The following is a description of a gene set: studied in species Mus musculus Genes predicted to be targets of miRBase v22 microRNA mmu_miR_147_5p in miRDB v6.0 with MirTarget v4 prediction scores > 80 (high confidence targets). Mouse Gene Set: MIR_147_5P from publication Chen Y, Wang X (PMID 31504780), and this is the list of marker genes: Sh3bgr, Foxo1 (NCBI Gene Id 99758), Zfp148, Fam222b, Calhm5, Milr1, Kcna2, Rora, Cntn3, Cldn8, Crkl, Mex3c, Shprh, Ccdc122, Nae1, Pcdh19, Bmp5, Chic1, Wdfy1 (WD repeat and FYVE domain containing 1), Tmem243, Clint1, Dact1, Lmbrd1, Cul4a, Usp48, Tenm3, Tbl1xr1, Ammecr1l, Oxa1l, Sgcz, Mdp1, Cnih1, Slc4a7, Herc3, Kmt2c, Tyro3, Rpa1 (replication protein A1), Ubfd1, Ccr1, Krtap4-9, Ankrd69, Cmtr1, Clock, Mmp21, Ncor1, Pclo, Gjc3, 1700030J22Rik, Aff3, Otud5, Pakap, Hltf, Sft2d3, Dzip1, Ro60, Tipin, Atp10a (ATPase, class V, type 10A), Zfp91, Ino80d, Crppa, Paqr9, Tcf24, Ppbp, Stil, Cpq, Astn1 (astrotactin 1), Cdc42se2, Heatr5a (NCBI Gene Id 320487), Fam89a, Bmal1, Map3k1, Otud4, Fxyd6, Ovol2, Anxa9, Extl2, Abcd3, Il1rap, Matcap1, Otud1, Senp2, Gpm6b, Sox13, Pde4d, Rnf152, Rsu1, Psg28, Rgs5, Adcy6, Prlr, Kcnb1, Mphosph10, Zfp706, Nedd9, Elp1, Dock10, 1700025G04Rik, Cnot6l, Tecpr2, Unc5d, Tmem200a, Laptm4a, Sh3pxd2a, Cracdl, Gabpb2, Fam120a, Slc8b1, Akr1d1, Tet1, Mcm8, Col4a6, Phf8, St6gal1, Sgip1, Amy2a2, Mylip, Zfp568, Ano3, Gbp4, Ino80, Rngtt, Srsf4, Ubqlnl, Krt81, Dclk1, Insyn2a, Macir, Atg4c, Htr3a, Maf1, Tmem98, Ppp2r1b, Tbl1x, Serinc5, Hnrnpd, Rnpc3, Mettl15, Vash2, Akap10, Wnk3, Creb3l2, Cers3, Picalm, Rc3h2, Ppp2r5e, Stk32b, Tnrc6b, Kras, Gdf2, Cbl, Zbtb34, Scn7a, Rab33a, Eif1b, Tcf20, Tpm2, Nav3, Larp1b, Klra1, Tfcp2l1, Gucy1a2, Robo2, Pabir2, Clec4d, Ist1, Zfp772, Tcf23, Six4, Tcf7l2, Tmem18, Cep97, Fam161b, Tgfb2, Ranbp9, Zc3h12c, Cep170, Mbnl3, Cntnap2, Med13l, Arhgef12, Efr3b, Slf2, Hdlbp, Dpp10, Mfap3l, Aak1, Pced1b, Tmed8, Pik3r1, Ptprk, G3bp2, Pds5b, Ntaq1, Pou4f1, Trim33, Smg6, Arid4b, Amy2a3, Phrf1, Xiap, Dtx4, Ces1g, Klhl14, Rap1b, Ago3 (NCBI Gene Id 320115), Lcorl, Htr4, Chrnb2, Cfap107, Emp2, Syk, Pfn2, Nup35, Prkab1, Tle1 (transducin-like enhancer of split 1), Gm20736, Nfib, Negr1, Pi4k2a, Rcan1, Eml4 (NCBI Gene Id 78798), Sly, Ebag9, Sbno1, Pnma2, Pafah2, Kdm5a (lysine demethylase 5A), Rbm48, Arhgap30, Sec11a, Anks1, Vcf1, Scrg1, Twist1 (twist basic helix-loop-helix transcription factor 1), Prorsd1, Gosr2, Ttc41, Zdhhc5, Aar2, Tmem167, Dusp16, Ikzf1, Slc8a1, Igsf3, Tmem269, Zfyve16, Xkr4, Rnf166, Agk (NCBI Gene Id 77076), Tanc2, Lrch3, Tsen34, Cenpw, Gmfb, Amy2a4, Rabgap1l, Ubxn7, Gm5622, Glyr1 (NCBI Gene Id 74022), Caps2, Atp6v0d2, Cd200, Rps6ka6, Cacybp, Elapor2, 4921517D22Rik, Phip, Eral1, Zic3, Ncam1, Map1b, Siae, Sez6, Pcdh7